The following is a description of a gene set: Mouse Gene Set: GOBP_REGULATION_OF_RRNA_PROCESSING species: Mus musculus Any process that modulates the frequency, rate or extent of rRNA processing., and this is the list of marker genes: Utp15, Bud23, Ncl, Heatr1, Ythdf2, Sirt7, Wdr43, Wdr75, Riok1, Mettl18 (NCBI Gene Id 96883), Nudt16, Dimt1, Kat2b, Riok2, Trmt112, Usp36